Given this list of marker genes Creb3l3, Alpk3, Amot, Pgm2, Mob3c, Nrp2, Xkr4, Pafah1b1, Meis3, Ppan, Rbm33, Ctns, Relch, Adamts9, Homer1, Tbkbp1, Syn1, Capn6, Agpat4, Myo18a, Celf5, Krtap4-2, Stox2, Helq (helicase, POLQ-like), Aak1, Nup98, 4933430I17Rik, Asb12, Nectin4, Hecw1, Lin52 (NCBI Gene Id 217708), Scai, Lyrm1, Slc35c1, Camk1d, Anks1b, Pla2g3, Rnf39, Klhdc3, Grk5, Slamf6, Gls, Ankrd45, Rnd3, Csnk2a2, Eya3, Fbxo28, Ldhb, Eif2ak3, D630045J12Rik, Sertad2, Cgnl1, Tchh, Tent2, Fcrl5, Mapk8, Fubp3, Pogk, Pbx1 (NCBI Gene Id 98516), here is a description of the gene set: Genes predicted to be targets of miRBase v22 microRNA mmu_miR_1843b_5p in miRDB v6.0 with MirTarget v4 prediction scores > 80 (high confidence targets). Mouse Gene Set: MIR_1843B_5P from publication Chen Y, Wang X (PMID 31504780) species: Mus musculus